Given this list of marker genes HDAC5, MAML1, KAT2A, NCOR2, HDAC7, HDAC6, KAT2B, HDAC4, RBPJ, HDAC2, SNW1, HDAC9, HDAC10, NCOR1, HDAC8, NOTCH3, HDAC11, CREBBP, NOTCH4, MAML2, MAMLD1, MAML3, NOTCH1, TBL1X (transducin beta like 1 X-linked), NOTCH2, TBL1XR1, HDAC1, HDAC3, here is a description of the gene set: Notch-HLH transcription pathway Human Gene Set: REACTOME_NOTCH_HLH_TRANSCRIPTION_PATHWAY species: Homo sapiens